Given this list of marker genes PLP1, FRA10AC1, RBM8A, LBR (lamin B receptor), MED25, CDK10, ASXL2, CDK13, here is a description of the gene set: Naevus flammeus localized in the skin of the forehead. Nevus flammeus of the forehead species: Homo sapiens Human Gene Set: HP_NEVUS_FLAMMEUS_OF_THE_FOREHEAD